Given this list of marker genes AQP1, AQP6, RHBG, RHCG, RHAG, here is a description of the gene set: species: Homo sapiens Human Gene Set: GOBP_CARBON_DIOXIDE_TRANSMEMBRANE_TRANSPORT The process in which carbon dioxide (CO2) is transported across a membrane.